The following is a description of a gene set: Mouse Gene Set: MULLIGAN_NTF3_SIGNALING_VIA_INSR_AND_IGF1R_UP Genes similarly up-regulated in 3T3-L1 cells (fibroblasts able to differentiate to adipocytes) upon stimulation of INSR or IGFR1 by NTF3. from publication Mulligan C, Rochford J, Denyer G, Stephens R, Yeo G, Freeman T, Siddle K, O'Rahilly S (PMID 12213819) studied in species Mus musculus Insulin and insulin-like growth factor-1 (IGF-1) act through highly homologous receptors that engage similar intracellular signaling pathways, yet these hormones serve largely distinct physiological roles in the control of metabolism and growth, respectively. In an attempt to uncover the molecular mechanisms underlying their divergent functions, we compared insulin receptor (IR) and IGF-1 receptor (IGF-1R) regulation of gene expression by microarray analysis, using 3T3-L1 cells expressing either TrkC/IR or TrkC/IGF-1R chimeric receptors to ensure the highly selective activation of each receptor tyrosine kinase. Following stimulation of the chimeric receptors for 4 h, we detected genes to be differentially regulated, of which 10 were up-regulated to a greater extent by the IGF-1R. These included genes involved in adhesion, transcription, transport, and proliferation. The expression of mRNA encoding heparin-binding epidermal growth factor-like growth factor (HB-EGF), a potent mitogen, was markedly increased by IGF-1R but not IR activation. This effect was dependent on MAPK, but not phosphatidylinositol 3-kinase, and did not require an autocrine loop through the epidermal growth factor receptor. HB-EGF mitogenic activity was detectable in the medium of 3T3-L1 preadipocytes expressing activated IGF-1R but not IR, indicating that the transcriptional response is accompanied by a parallel increase in mature HB-EGF protein. The differential abilities of the IR and IGF-1R tyrosine kinases to stimulate the synthesis and release of a growth factor may provide, at least in part, an explanation for the greater role of the IGF-1R in the control of cellular proliferation., and this is the list of marker genes: Nme1, Coro1c, Ddx21, Wdr77 (NCBI Gene Id 97079), St6gal1, Srsf2, Serp1, Grem2, Ebna1bp2, Mrpl20, Usp10, Gnl3, Hspa4, Srxn1, Ccl2, Arl4c, Nop56, St3gal4, Rcl1, Gmppb, Bnc1, Tmem97